Given this list of marker genes HSD17B14, SEMA6D, POU1F1, INHBA, NCAN, RNF43, FRA10AC1, RFX3, SYNE2, SALL1, TBXT, NDST3, LAMA3, OTX2, MFN2, SLC24A4, SOSTDC1, CD2BP2, HOXA2, SCLT1, OVOL2, GADD45A, MORF4, RBM42, DNAJC22, LRRTM3, LGALSL, KDM3A, TNMD, R3HDML, MAP3K20, PPP2R5C, PHYHIP, HIP1, SH3TC2 (SH3 domain and tetratricopeptide repeats 2), ADAMTSL1, DDX17, LIN28A, CHCHD7, GUCY2F, PLA2G4A, DOCK3, KRT36, GPC4, USP2, MBP, CFHR3, AMBN, HOXD12, DYRK3, SKIDA1, XRCC5, DCN, DNAJB5, VSTM2L, USP3, LINC01559, CREM, MYL3, IKZF3, EN1, KRTAP15-1, UBE2U, CREB3L2, LINC01089, A1CF, HEY1 (hes related family bHLH transcription factor with YRPW motif 1), SMO, AMMECR1L, MED12L, TF, IL31RA, RORA, ITSN2 (intersectin 2), CAB39, PRRX1, OTP, CADPS, NRG1, SPINK5 (NCBI Gene Id 50962), STIM2, COL18A1, PDC, LRCH2, CLEC4D, GTF2A1L, CDH13, FILIP1, CLTC, FGF10, NKX6-3, DMD, TFAP4, HSD11B1, TGM1, LRP2, AGXT2, HAS3, CDCA3, TBX3, DNAJC14, PCSK1, SPTLC3, ACTR1A, MAGED2 (NCBI Gene Id 10916), POU5F1, GABRB2, SLC38A5, LY6G6E, NEXN (NCBI Gene Id 91624), SLC14A1, USP34, DNAJA2, MAP4K3, RPL23A, IL22, QRFP, OSBPL8, XK, AMMECR1, SMIM12, MYH4, UBE2D3, TIAL1, NXPH3, ARHGAP36, HBP1, MED26, MYOT, CDH6, PBX2, NEDD8, CHRNA1, HAL, CHN2, PPP4R2, ZC3H6, RAB30, EIF4A2, MITF, ZC3H18, URGCP, SERTM1, AOC2, DUSP10, AARS2, KCNJ1, CD3D, NOG, ZMAT4, CEP97, LRP8, SV2A, JDP2, COLCA1, PANK1, USP32, POFUT1, MYH2, PCGF5, SLC6A4, NHLH2, ESRRG, RNF14, EIF5, C9, SYNPR, TRIM9, RTL10, RFLNB, SSH2, OSTF1, ENPP1, SP8, KRTAP11-1, TMEM256, ACSL5, BARX2, ESRP2, ILRUN, VAX1, RESF1, GSDMA, CCR7, MPP2, KRT23 (NCBI Gene Id 56668), POU4F3, PCDH18, ROCK2, ACSL3, PTPRO, AIF1L, CPS1, MIDEAS, PARP11, NIPAL2, PER1, H1-0, ITGB6, TMIGD1, POU3F4, KRTAP19-6, PMEPA1, RFTN2, KERA, HOXC4, LINC00671, DLX1, HTR2B, DNTTIP1, USP5, SLITRK4 (NCBI Gene Id 139065), SH3BGRL, NINJ2, NEUROD4, ITK, NR2E1, AP1G2, PPAN, KCTD15, ERAS, GARIN2, BACE1, OR10A5, ZIC4, SRRM4, CREB5 (cAMP responsive element binding protein 5), NR2F1, TTYH2, EMC7, SLC6A9, RAB24, XPO7, FBP2, DNAJC7, KCNQ1DN, TMEM71 (NCBI Gene Id 137835), INVS, ASB13, OGG1, USP31, SLC5A3, RALGPS2, CDK15, DARS1, TRIM33, TONSL, BSCL2 (NCBI Gene Id 84753), EEPD1, VCPKMT, HERC1, PITX2, NARS2, AHNAK, CORO1C, MYH8, AP5B1, RBM39, GPM6A, SLC38A6, HOXB7, GNG3, KMT2E, CSRNP3, SOX14, TRAF4, CD160, PCDHGA4, SYTL2, GPC5, POU2AF1, UTP23, IRAG1, CFAP65, DENND4A, AMPD3, PDYN, DMXL1 (Dmx like 1), MPZ, GSS, GIGYF2, CARD10, C1QTNF6, MLLT6, TMEM8B, ATOH1, UBR5, PIM2, HOXB9, RNF11, PPFIA3, HIF3A, STEAP2, CDKN3, TCEANC2, ELAVL2, FAM170A (family with sequence similarity 170 member A), TGIF1, NDUFS3, PLA2G4B, ARHGAP20, INO80, MMP21, TTC39C, UBE4B, PTHLH, KRT18P55, CFB, GAPDH, LAMB2, CTSC, KCNH5, HS6ST3, SOCS2, SLC43A3, CMYA5, CDC25C, GFPT1, SHF, OTX1, SPTAN1, NPVF, KITLG, SLC16A9, RGS3, CACNA2D2, ANKRD28, PDE11A, PKHD1L1, PRDM1 (NCBI Gene Id 639), MBNL1, ALDH6A1, GRK5, SORD, ZHX2, SCP2D1, C12orf42, LMO1, ZNF521, EPHA2, DMP1, CSNK1G3, BAG2, ZBTB41, CEP95, PPM1L, RRM1, RNF213, TBC1D8, ETS1, SLN, MME, CDH9, OVOL1, FGF20, DSG1, SMYD2, NBEA, RUNX3, CELA1, GBX2, ITGA1, BEST3, CALHM5, SIX4, ARX, PTMA, SESTD1, ORMDL3, KCTD6, SMIM29, DAO, NCBP3, ABI3BP, IKZF2, NPSR1, SLC22A8, TAB3, RANBP10, LAPTM4B, FGF17, GRIA3, TNXB, BRWD3, PCNX2, NFE2, TP53I13, ELF5, SPO11, DAB2IP, ZFYVE9, EYA1 (EYA transcriptional coactivator and phosphatase 1), CDX1, OSBPL6, WDR5, MANEA, ZNF488, AFF3, RABL6, SPSB2, CRYBG2, AGBL5, TMSB4XP4 (TMSB4X pseudogene 4), GRK2, ADGRL2, IDH3G, CMTM2, SPACA7, PCDHGC3, NEDD4L, SACM1L, RAB5C, WDR1, WNK1, CRH (corticotropin releasing hormone), ARID1A, BSND, RGS12, PALS2, CKAP4, MAOB, HAPLN1, RSPRY1 (ring finger and SPRY domain containing 1), ZNF597, ETV5, FUT8, USP49, CNR2, HOXB2, TOB1, MRPL1, KRTAP19-2, BMI1 (NCBI Gene Id 648), HOXB4, MEIS1, PCDH1, MPPED2, PRDX4, TMEM38B, DOCK11, COL11A2, KYNU, NKIRAS2, TSPAN2, SLC17A2, RARB, PDGFA, STAC2, DLL4, PRDM2, LIMK2, COLQ, WNT9A, FZD10, EMG1, SCML2, PHC1, ELOVL1, EVA1A, PANK2, RABGAP1L, AMER2, AP4B1, KIF7, PAK4, TRIM2, EXD2, MIR9-1HG, TFEB, MPPE1, AIFM3, DPH5, MAP4K5, CTHRC1, ENAM, MAP2K6, LHX1, MECOM, ENGASE, S100A3, SLC39A8, EPHA7, HADH, DPYD, PLXND1, PRSS33, BARHL2, C4orf33, NAV2, MED13 (NCBI Gene Id 9969), PDPN, CPNE4, SDHC, SFRP2, SCG3, STEAP1B, KRT85, NXF1, VXN, TTI1, SEPTIN4, MYF5, CD226, DSCAM, RERE, CTNND1, CASZ1, STRA6, ASPH, KRT35, NFIL3, HEY2, STAG2, STX5, MEIS2, OTC, COL13A1, KRT33A, XKRX, PRDM13, C1S, KBTBD2, RTF2, CLCNKA, KBTBD4 (NCBI Gene Id 55709), RRAGD, TARS2, TAGAP, EFNA4, NXPH1, GRAP2, CMAS, HOXA4, KBTBD12, NR2F2, SNCAIP, TTN (NCBI Gene Id 7847), CDIN1, ERG, SCG2, NEUROG3, CA4, PRUNE1 (NCBI Gene Id 91961), GABARAP, SGIP1, SNTG1, KDM6A, WNT10B, TRMT1L, TNFRSF19, NPNT, KLF3-AS1 (KLF3 antisense RNA 1), TBR1, COX7B, ZFP36L1, WFIKKN2, ZEB2, UBR3, DHRS11, HAND1, KIF4A, PCBP4, ZBTB18, SCRG1, LIFR, MALL, RTN1, MT-ND2, PALS1, KHDRBS2, SLC17A6, EED, MCTS1, C19orf73, INHA, NYAP1, FEM1C, XCR1, DES, PPP1R1B, KCNJ14, BGN, SPRY4, FAT1 (NCBI Gene Id 2195), IL20, LINC02915, FBXW7, PBX3, SLC30A3, NCDN, NMRK1, ACAP2, CNKSR2, YPEL3, SSTR3, CABP7, HOXB1, ELAVL4, RIMOC1, ZFHX3, NEDD9, ELMO2, KCNH8, NDUFC2, CBFA2T2, KLF3, SUSD2 (NCBI Gene Id 56241), ZNF827, CLIC6, CHODL, LPCAT3, OXCT1, APOO, NR4A3, YWHAQ, HOXA7, KLHL34, RASGRP3, RAB7A, UNC119, MFSD14A, ZNF8, SPAG9, TLE4, CUBN, CGN, RBP2, LRMDA, PFKFB4, BMP7 (NCBI Gene Id 655), SIPA1, HOXC11, JPH2, RPRD1B, AHCYL1, RET, TDRD10, EDA (NCBI Gene Id 90878), PGAP2, RGMA, MARCHF10, DTNA, DPF3, ELK3, CKMT1B, PPP2R3C (protein phosphatase 2 regulatory subunit B''gamma), URI1 (URI1 prefoldin like chaperone), MAP4K4, RNF5, CFHR5, EFNA5, SNX17 (sorting nexin 17), TSPAN12, KRT81, NDP, EMP1, PSMF1, NIPAL3, BHLHE40, ALCAM, DQX1, RRH, RNF2, SLC24A1, BNIP3L, BMPR2, TCERG1L, TCF4, LHX2, UBAP2L, TBC1D8B, FZD7, CLSTN2, SEC24B, CASQ1, ADAM12, IL1RL1, WNT8B, ZC3H11A, WBP2NL, CASK (NCBI Gene Id 8573), EDDM3B, ABR (NCBI Gene Id 82701), WDR35, SLC25A10, PUM3, ANK3, FEZF2, AGPAT1, ARHGEF6, TTC29, TSG101, TCF12, EGFLAM, EHBP1, RPA2, CELF4 (CUGBP Elav-like family member 4), CDYL, GNG8, CLDN15, WNT6, SORBS1, INTS9, BMS1P20, TNFSF13B, WNT2, CS, TAOK3 (NCBI Gene Id 51347), KY, CSNK2A1, CSTF1, EMID1, SUZ12, GYS2, TRIAP1, TAS2R5, FOXN3, ABCF2, BCL6, SERPINC1, ZC2HC1C, MYF6, CLINT1, ZNF703, HOXB6, KLHL7, CXCR4, LEMD1, JADE1, RGL1, TBX21, MTRF1L, SLC13A2, SH3RF2, GTF2A1, STX1A, GMPR2, HOMEZ, HNRNPA2B1, MINDY1, CUTA, TP63, TMSB4XP6, ZC4H2, EIF2B4 (eukaryotic translation initiation factor 2B subunit delta), SENP1, TFDP2, DACH1, RCN1, TAFA1, HOMER2, KRT8P41 (NCBI Gene Id 283102), PIK3CG, FOXA1, WNT3, IGDCC3, KCTD4, VNN1, AKT2, ARHGEF38, PCK2 (phosphoenolpyruvate carboxykinase 2, mitochondrial), KLHDC8A, PTCH1, KIZ, RNF24, SGCD, CDC25B, MPLKIP, IL1RAPL1, OIP5, PAM, KCNIP4, SNAP25, ABHD2, ATXN7L2, SLC22A23, PSMD11, ADAM9, MLXIP, MAPRE1, KRT32, KRT33B, MOV10, LYG2, CLUH, TMSB4XP8, HMCN1, TEX12, FBXO32, HABP2, AURKA, JAG1, GDNF (glial cell derived neurotrophic factor), EIF4EBP2, ARID5A, COL15A1 (collagen type XV alpha 1 chain), SEMA4B, SNX18, IL18R1, PAX3, CHRNA9, HCAR2, RNF145, PDZD11, DDX39B, PPARG, MEF2C, FIGN, SMARCC2, PELO, FGGY, AK9, PSMB5, RAPH1, CDK1, ICA1, TNFRSF17, TMEM164, PIK3R1 (phosphoinositide-3-kinase regulatory subunit 1), SMG7, PBRM1, ATP13A4, WFDC3, GSTCD, TCF7, HNF1B, GOLPH3L, MAB21L1, MEOX1, PART1, LETM2, TENM3-AS1, CAVIN2, SLC6A10P (solute carrier family 6 member 10, pseudogene), RRBP1, ARPP19, PURA (purine rich element binding protein A), CYP2E1, PRR16, RLBP1, GLI2, FAR2, FERD3L, SMC2, GLYR1, PRMT3, POLR2C, ACIN1, EDDM3A, SCN3A, FAM110D, NECTIN4, MORC4, UBE2F, PPARGC1A, EYA2, TMEM51, TNKS, NEUROG2, DLG2, SLC4A4, ARL3, AP1S2, TLE1, BRCA2 (BRCA2 DNA repair associated), TMEM51-AS1, GPBP1, ZNF516-DT, CALM3, LINC03042, TBXAS1, TMSB4XP1, TSHZ3, MAZ, ARL6IP1, GOLGB1, HOXC6, ENPP2, SLITRK2, GOLGA1, EIF4G1, DYNC2I2, ISL1, CXCR5, CD40LG, COL5A1, ZBTB32, NFATC4, TCERG1, TLL2, MTFR1L, CHIC2, MT2A, TSPAN7, DSG3, SESN3, GFPT2, PLA2G4D (NCBI Gene Id 283748), ACVR1B, MESP1, ASS1, SEMA3A, CHD2, SLC13A5, CNTN6, NKD1, ABHD15, PLAC1, GABRG2, SLC26A3, CCDC71L, MOSMO (NCBI Gene Id 730593), ADD3, DKK1, PIM1, NSD1, PCTP, CD27, INA, AKAP1, ETV1, SOAT1, TSR1, ABCD2, SCAMP3, CYTH3 (cytohesin 3), EBF2, ANKS1B, TACSTD2, MAPK10, HNRNPR, PTCH2, MYCL, MEOX2, KCNJ2, EIF4E, DCAF7, MYL1, EIF4EBP3, LYSMD1, MYEF2, LRRTM1, FER1L6-AS1, NUSAP1 (nucleolar and spindle associated protein 1), APBB2, CDC42EP3, RINT1, EML4, GNA12, CA12 (NCBI Gene Id 771), DLX5, KRT83, INTS12, PCDH7, CDX2, EDN3, MYOF, LINC00310, MAFF, ASCL4, IL10RA, TMSB4X, CHGA, EEF1AKMT1, RFX4, PLAG1, MT-CO1, ANKRD44, FOXP2, NEUROG1, AGFG2, HOXA3, AR, GTF2A2, LRRN3, AP3B2, PLAGL2, HSF4, SLC34A3, TENM1, NCKAP5, SPATA32, CXorf58, LHX4, TMEM52B, ABCD1, DCT, MCC, SATB1, G6PC1, EBAG9, CTLA4, CRAMP1, F11, EIF4G2, POLR2M, FGF19, C16orf74, SETD2, ODF2, SOX21, CNTF, IQGAP3, RNF19B, RUNX1T1, ROBO4, NRK, EMC10, RASAL2, ZBTB20, TMEM182, NFE2L1, TMEM59, HNF1A, FKBP11, DGKH, SGK3, COL2A1, CEPT1, LINC01101, PCM1, GAS7, NKX6-1, SH2D1A, PCYT1B, TMEM141, PAPLN, SMARCA2, DDR2, PRELID1, PSME3IP1, CYP19A1, SLC27A4, ANKFN1 (NCBI Gene Id 162282), SCNM1, FSIP2, ADGRA2, TSHZ2, TTC8, ERBB4, CPNE1, CCR1, ROBO1, DCHS1, FMR1, HIBADH, FST, OPCML, FBXW9, CNTFR, PLEC, CSNK1A1L, ZNF710, SPOCK2, GFRA1, ADGRB2, MID1, GPR151, CHMP4B, SCUBE2, SCUBE1, SSR4, UBE2Z, ADAMTS19, TSKU, NDC1, KCNJ13, ARMH3, FAT2, SMAD1, TMEM214, C1QTNF7, DHCR24, CDC42BPB, DLC1, LAMP2, SEMA4G, RNF39, CNTLN, SRSF5, LRRC1, IL18RAP, ENTPD7, DCLRE1B, PSIP1 (NCBI Gene Id 93428), ADAMTS12, CISH, RUNX1, RALYL, ITGAM, TMEM156, SCN2B, ARNT, PDE1A, XRCC6, CRLS1, CASP8, NPPA, SLC7A8, CHRDL1, HOXB3, NRP2, OFCC1, TIMM10, PHTF1, NTF3, NKX2-8, PPP2R2B, TSPAN13, PHB2, MSI2, SLC25A28, MAML3, NEUROD1, STEAP1, FGF18, ACSS3, SLC44A1, PLSCR1, ARK2N, SYTL1, SLC35B1, CRYGD, HMBOX1, NEK7, VIP, PRRT3, ISOC1, NEO1, RCOR2 (REST corepressor 2), GPHB5 (glycoprotein hormone subunit beta 5), SOX6, OTUD5, ARPP21, THAP12, PROX1, MSX1, ELOVL4, SUCLG1, TP53BP1, SCRT2, PFN1, GNB1L, FGF14, ZPBP2, EDEM3, HOXD3, LDOC1, YARS1, LINC00518, SULF1, BMP1, VIT (NCBI Gene Id 5212), UCP2, TNFAIP1, GBF1, C14orf119, TBL1XR1, SLC6A14, MANSC1, FABP4, TMEM117, SULT2A1, HOXA13, MB21D2, RSKR, TM2D2, COL11A1, UBE2E2, TRPM1, TMEM147, GAB2, VGLL4, MEP1A, SLC22A12, HLTF, PID1, PGBD4, SP4, CD247, UBE2A, NSL1, VWA3B, ALS2, ENPP5, HOXA11, NMB, UBE3A, HOXC5, CYGB, CDH3, NCALD, PRKCB (NCBI Gene Id 5579), ZIC1, RXFP2, CXXC5, CPB1, ZNF462, UAP1, GPX2 (glutathione peroxidase 2), SOX5, KCNK18, PXK, MNAT1, GLUD1, TAT, NRXN1, SHKBP1, LEF1, SNORC, UBALD2, ACTR3, PMP2, SLC26A9, TCF7L2, LMO7, FOXA2, HOXA10, SREK1, GPRIN3, HAS2, CYB561D1, ELMO1, NFIX, ARHGAP6, WWP2, NPR3, ERP27, HCFC2, CD274, ANXA3 (annexin A3), PCDH8, CYTOR, VSNL1, AKTIP, JOSD1, WDFY3, YPEL5, SORCS1, CEP350, IFT20, NLK, LAMP5, IL19, PAX6, SFXN2, FGFR3, GALNT17, UBE2D1 (NCBI Gene Id 9335), here is a description of the gene set: Genes having at least one occurrence of the highly conserved motif M73 CTTTGA in the regions spanning 4 kb centered on their transcription starting sites. This matches the LEF1 transcription factor binding site V$LEF1_Q2 (v7.4 TRANSFAC). Comprehensive identification of all functional elements encoded in the human genome is a fundamental need in biomedical research. Here, we present a comparative analysis of the human, mouse, rat and dog genomes to create a systematic catalogue of common regulatory motifs in promoters and 3' untranslated regions (3' UTRs). The promoter analysis yields 174 candidate motifs, including most previously known transcription-factor binding sites and 105 new motifs. The 3'-UTR analysis yields 106 motifs likely to be involved in post-transcriptional regulation. Nearly one-half are associated with microRNAs (miRNAs), leading to the discovery of many new miRNA genes and their likely target genes. Our results suggest that previous estimates of the number of human miRNA genes were low, and that miRNAs regulate at least 20% of human genes. The overall results provide a systematic view of gene regulation in the human, which will be refined as additional mammalian genomes become available. studied in species Homo sapiens Human Gene Set: CTTTGA_LEF1_Q2 from publication Xie X, Lu J, Kulbokas EJ, Golub TR, Mootha V, Lindblad-Toh K, Lander ES, Kellis M (PMID 15735639)